Given this list of marker genes PHOX2A, DDX6, LOXL1, TMEM67, TUBB3, KIF21A, SH3TC2, AAAS, TUBB2B, KCTD1, COL25A1, SIN3A, PMP22, TUBA1A, GMPPA, here is a description of the gene set: Human Gene Set: HP_ANISOCORIA Anisocoria, or unequal pupil size, may represent a benign physiologic variant or a manifestation of disease. species: Homo sapiens Anisocoria